Given this list of marker genes TXNDC15, RPL10, IFT122, MAPRE2, DST, SRD5A3, KCNQ1OT1, RAC1, KDM6B, TUBGCP6, SKIC3, WBP4, LRPPRC, CSGALNACT1, DOCK6, ADAR, INPP5E, ATP6V1E1, IDH1, CNTNAP1, MAFB, FOXI3, FAT4, TAF1, PGAP2, RREB1, POGZ (NCBI Gene Id 23126), PAX7, SMG9, TAF6, CCDC47, GTF2E2, SIN3A, WLS, NOTCH2, GTF2IRD2, INTU, ZNF711, SLC39A7, NDUFB11, SLC25A1, RALA, TRAIP, PGM2L1, COLEC10, HSPA9, DBR1 (NCBI Gene Id 51163), COG1, EZH2, NECTIN1 (nectin cell adhesion molecule 1), CHN1, IGLL1, PEX11B (peroxisomal biogenesis factor 11 beta), HNRNPK, THUMPD1, POC1A, POLR1A (RNA polymerase I subunit A), CCNK, AFF4, TTC8, LMNA, TCTN3, WFS1, RELN, SLC16A2, HOXA2 (NCBI Gene Id 3199), SNAP29, NEU1, PACS1, DDB1, BRCC3, RNASEH2A, DOCK7, ZEB2 (NCBI Gene Id 9839), CHRND (NCBI Gene Id 1144), PPP2R3C, CRLF1, CENPE, RFX7, DLL3, NRCAM, POU4F1, MPLKIP, BRWD3, LMNB1, TMEM138, LONP1, ARL13B, SLC25A12, CEP104, WAC, EFEMP2, RNU4-2, UFD1, MINPP1, WWOX, ALG6, GREB1L, POU3F3, INTS1, FN1, ASXL2 (NCBI Gene Id 55252), SMC1A, CTH, RFWD3, STEEP1, H19, FGD1, CEP41, CILK1, YRDC (NCBI Gene Id 79693), RRAGC, BBS12, ARID2, DHPS (deoxyhypusine synthase), COL7A1, SLC39A8, LETM1, USP7, RAB3GAP2, ASXL3, LMBRD1, RAB34, GLI3, LZTR1, FRA10AC1, FREM2, HES7, MAPK1, ADA2, AIP, RPS17, SLC12A2, RPGRIP1L, THOC2, MYO18B, UBA2, COX7B, SATB2, ERI1, CLTC, SLC37A4, MAP2K1, SKI, TTI2, CRELD1, NR2F1, DPYD, CACNA2D1, CTU2, CCDC8, MEGF8, LUZP1, KDM5B, BCL11A, ECE1, WNT9B, TCF4, PPP1CB, PUF60, CBY1, CLIP2, GLI2, LRRC8A, RASA2, RFC2, PI4K2A, ALX3, ASPRV1, HGD, PALB2, CPE, SULT2B1, VAC14, NEK1, UBAP2L, MADD, PIGN, PGAP1, AP1G1, BMP1, GFRA1, PUS7, CUL7, BLTP1, PORCN, SAMHD1, AASS, ALX1, KAT6B, SIX2, CLCNKA, TBX22, FIBP, DDX6, POMK, ANKRD11, ACTA1, EVC2, PRDM16 (PR/SET domain 16), PREPL, PSMB8, CEP290, MYMX, RPL31, COMT, KMT2A, TRIM32, ZNF668, VPS13B, BBS9, TNNT3, RNF2, PAH, PIGA, BRAF, CBL, WDR73, NDST1, CASK, NFIA, FBXL4, NSD1, DHX30, OGT, TBX1, TCF20, RBBP8, RPL8, CYP4F22, HOXB1, NDE1, NFIX, HYMAI, CARS1, ERF, ALOX12B, DRG1, GJA8 (NCBI Gene Id 2703), B3GAT3, TMEM147, B9D1, RALGAPA1, DNM1, ADAT3, ODC1, AFF2, LSS, TSHZ1, RPS15A, INPPL1, MSL3, HS6ST2, NSUN6, SPTBN1, MEIS2, HBA1, FKRP, HNRNPH1, SPECC1L, NAA20, GATA1, RNASEH2C, TRIP13, PMM2, MN1, TBX15, TGDS, KMT2C, TAF4, IFIH1, GNPTAB, FANCM (NCBI Gene Id 57697), RAB23, FANCC, NKAP, SRRM2, ADAMTSL1, ADAMTS2, TARS1, RPS10, SHANK3, CHST14, BRIP1, GLE1, FRMD4A, BAP1 (NCBI Gene Id 8314), ADSL, DLX4 (NCBI Gene Id 1751), SCNM1, SIM1, PKHD1, CWC27, EIF5A, RPL18, MBTPS1, BMP2, PDE6D, YWHAE, ALKBH8, SMCHD1, CHMP1A, RHOBTB2, ZNF148, TMEM216 (transmembrane protein 216), HYLS1, SET, PRR12, VPS35L, ARL6, TEFM, NUP107, TMCO1, COL2A1, XYLT2, PHACTR1, RAD21, PTCH1, GJA5, RAD51, GPX4, POLR3A, CIT, U2AF2, KLF13, H4C9, BLNK, RECQL4, KCTD1, DNMT3B, CAMKMT, TAOK1 (TAO kinase 1), GRB10, SLC26A2, ATR, KIF7, TUBB3, RET, MECP2, EDN1, SLC25A24, NXN, RPS27, GTF2I, TMEM237, SUFU, LMX1B, FMR1, TRMT1, SLC6A9, UBE3B, ABHD5, AMER1, MRPS2, CANT1, ZFX, ETFDH, IPO8, RBM8A, SPINT2, KLHL41, NUP88, DENND5A, PAK1, MARS2, TBC1D20, SETD1A, NR4A2, ADNP, MAD1L1, FGF3, SLC6A8, PPM1B, UBA1, AHSG, IGBP1, DVL1, ORC4, YY1, TBR1, SOX5, ACP5, UPF3B, SOST, FRMPD4, SUZ12, RXYLT1, MMP23B, XYLT1, ALG2 (ALG2 alpha-1,3/1,6-mannosyltransferase), FLNA, RNF113A, GPRASP2, FTSJ1, HDAC9, PHIP, UHRF1, ATP6AP2, SLX4, KMT2D, POLR1C, LFNG, SOS2, FGFR2, CHRNA1, SIX5, GNB1, ETFB, SMS, WDR19, AMMECR1, EEF1A2, RPS7, KYNU, FANCA, HHAT, FOXP2, SMARCD2, RPL9, NELFA, FANCI, COG5, RAB5IF, ROR2, EVC, MID2, SBDS, DZIP1L, RPL35, KIF21A, AP4E1, MRPL12, PIGV, NSRP1, C12orf57, RPL35A, SEPTIN9, COL5A1, AHDC1, SLF2, FRAS1 (NCBI Gene Id 84949), ZMPSTE24, KDM5C, CLCNKB, DVL3, RIPPLY2, PIGO (phosphatidylinositol glycan anchor biosynthesis class O), CPLX1, PHGDH (NCBI Gene Id 94672), ZNF292, TBX2, C2CD3, PEX26, NAA80, AGO2, CCDC32, GK (NCBI Gene Id 2710), TASP1, UGDH, GDF11, RPS20, PLK4, KCNK4, CCDC22, FGFR3, FGFRL1, RPL11, TBL2, FANCL, TMEM231, TMEM94, GNS, INTS11, PIGL, AP3B1, VANGL2 (NCBI Gene Id 57216), ABCC8, ADAMTS15, NOTCH3, NDP, CFAP418, RAPSN, NTNG2, PNPLA6, RPS19, HSPG2, PRPS1, RNU4ATAC, CTBP1, EPG5, CUX1, EXOC2, TALDO1 (NCBI Gene Id 6888), BBS4, CASZ1, ATP6V0A2, ITGB6, SON, CSPP1, TP63, INSR, ARID1A, LAS1L, NALCN, HECW2, BRD4, MRTFA, HS2ST1, PDZD8, RSPRY1, ERLIN2, RPS28, STAG1, IFT27, DPP6, RRAS2, MGP, SHOC2, NAA10, HBA2, GON7, TOGARAM1, SALL1, BCL11B, ZNF407, ERCC4, TSR2, PEX12, EXOSC9, TRIP11, BMP4, PAX3, UMPS, RTTN, POLR1D, STAC3, NIPBL, LRP2, ORC1, BICRA, PIGT, AGRN, ITCH, DPH1, ZNF526, TWIST2 (NCBI Gene Id 117581), SNRPB, CD96, SMG8, MESD (NCBI Gene Id 23184), TRPS1, RPS6KA3, CHRNG, SLC9A6, KCNQ1, CHAT, EIF3F, DCHS1, DYRK1A (NCBI Gene Id 1859), PIGQ, PIGK, TCOF1, AIFM1, DHCR24, RUSC2, NRAS, TBX4, WARS2, RPS29, PRKG2, IGHM, JUP, DEPDC5, KIAA0586, KCNN3, CAPN15, EMC1, IFT56, KATNIP, OCRL, SLC2A10, GSC, NBN, BAZ1B, CAMK2G, SMOC1, TREX1, UBR7, ZBTB20, VPS51, ALMS1, PEX2, ALG3, MRPS14, ATP6V1B2, GPC3, SCAPER, NHS, FBXW11, ALDH18A1, PITX1, KCNH1, RB1, SP7, POLR1B, TMEM260, SMC3, MCTP2, PEX3, FUCA1, GAD1, RNASEH2B, CHD7, ZMYM2, CLIC2, H4C5 (H4 clustered histone 5), VPS53, CD79A, PIK3CA, TP53RK, EXT1, GMNN, KAT6A, RAI1, SH3PXD2B, ACAN, CHST3, ZDHHC9, RAF1, ANTXR1, DLK1, PIGW, LIPN, GRIA4, CAV1, SF3B2, TBC1D23, CASP2, EBP, ATN1, SLC12A6, LSM11, FOXG1, CENPF, ZMYND11, TRMT10A, PIEZO2, CACNA1G, GPC4, HOXA13, HOXD13, MESP2, UBE2T, FOXF1, EIF4A2, SOX6, EXOC7, DSE, MYSM1, EFTUD2, DCPS, HMX1 (NCBI Gene Id 3166), PURA, VPS37A, RPL15, SLC1A4, CEP295, COL11A1, BSND, KDM5A, LGI4, DSP, STRA6, ALG8, ERBB3, CSNK2A1, HEATR3, MKKS, ACBD5, BCOR, MVK, SOX9, HMGA2, CA2, GRIA3, BMPR1A, GPR101, ANAPC7, COL4A1, SPEG, DPF2, TPM2, AKT1, KIFBP, TOR1A, ASH1L, CDC42, FANCF, PUM1, WNT7B, CHD5, MAN2B1, HMGB3, MUSK, OTUD5, SOS1, EDNRA, CTNND2, CAPRIN1, TTC5, SSR4, COG3, SCLT1, ARL3, MED12, SPRED2 (NCBI Gene Id 200734), ZIC3, NIN, PAICS, EGFR, IFT172, MED25, WDR35, UFC1, MKS1, TRPV4, PLOD3, PLCB4, RIPK4, PIGB, TNPO2, ALX4, SLC6A17, WASHC4, KDSR, CDC6, VAMP1, HSD17B4 (hydroxysteroid 17-beta dehydrogenase 4), TCTN2, IFT81, ADAM17, PIEZO1, CDT1, NUP188, EFL1, ERCC8 (NCBI Gene Id 2075), RIC1, TAFAZZIN, RSPO2, AARS1, SMAD4, MEF2C, ERMARD, PYCR1, BBS5, FOXP1, RPL27 (ribosomal protein L27), SOX11, TCF3, PLCH1, PCGF2, KLHL40, GABRD, WNT3 (Wnt family member 3), MLXIPL, ZNF423, GJB3 (NCBI Gene Id 91028), ITGA8, CDH2, ZSWIM6, PCLO, HIVEP2, PSAT1, TRAPPC9, GLIS3, ANTXR2, SDR9C7, NUP85, NCF1, MBTPS2, AHI1, FAM20C, MYO9A, DDX3X, COG7, BCR, ORC6, WNT5A, COL13A1, TRIP12, TMEM218, GLUL, CDCA7, TFAP2B, PRKCZ, B3GALT6, PRDX1, HELLS, FGFR1, VIPAS39, STAG2, BRF1, TMEM270, H3-3A, JAG1, STT3A, IFT140, PHOX2B, CHUK (component of inhibitor of nuclear factor kappa B kinase complex), MED27, DHX37, RAD51C, ACTG1, YME1L1 (YME1 like 1 ATPase), TXNL4A, AP1S2, SLC35C1, SPI1, MED13L, MSX2, KDM4B, CHD8, POLE, RPL26, CDKN1C, MAN1B1, UGP2, RAB3GAP1, VPS33B, ADAMTSL2, MAP2K2, H4C3, KIF15, FANCE, MPDZ, ARVCF, TOPORS, TSPEAR, MAP3K7, BUB3 (BUB3 mitotic checkpoint protein), TNNI2 (troponin I2, fast skeletal type), OBSL1, EXTL3, DCAF17, CCN2, PTPRF, TENM3, ALG13, CDH11, NANS, GPT2, FANCG (FA complementation group G), ADGRG6, ABCC6, IGF2, ADAMTS18, LAGE3, HECTD4, PTEN, RAB18, TTN, OPHN1, SEMA5A, MARS1, FGF20, TMEM70, GTF2H5, KRAS, LIG4, HDAC6, TBCD, RPL5, UNC80, KIF26A, ZC4H2, MACF1, XRCC2, KANSL1, SPIN4, MITF, GP1BB, MRAS, CHD3, TTI1, PSMD12, RAP1B, SCYL2, GTF2IRD1, HDAC4, IL6ST, BICD2, GPC6, UBE2A, HRAS, STX1A, MYCN, RBMX, ARMC9, ZNHIT3, PIGS, FBN2, HUWE1, ZNF462, ACOX1, BHLHA9, OTUD6B, FOXE1, ACTB, MAPK8IP3, PDE4D, TBCE, SLC3A1, EFEMP1, PSMB10, PYCR2 (NCBI Gene Id 29920), TRRAP, SLC5A7, AGO1, SPEN, PEX14, AFF3, PBX1, PGAP3, WNT4, SNAP25, EIF4H, KCNJ11, RARB, RPGRIP1 (RPGR interacting protein 1), KCNJ5, TMEM107, PEX10, TUBGCP4, MAF, CNOT3, ENPP1, PDPN, CHSY1, BPTF, HDAC8, ANK1, POMT2, PEX16, PIK3CD, RBM10, SCO2, QARS1, ASXL1 (ASXL transcriptional regulator 1), EIF4A3, B4GAT1, RPS26, EED, ATRIP, DIS3L2, IFT52, ABCA12, PSMC3, SPRED1, PLXNA1, OCLN, FGF10, ARX, SUOX, ITGA3, TBC1D24, BBIP1, CNOT1, NIPA1, POMT1, POMGNT2, VSX1, BRCA1, DDX59, MAP1B, CLCF1, KCNK9, STXBP1, GNE, ALG12, OTUD7A, METTL5, SMPD4, TOE1, NIPA2, PRUNE1, POR, RDH11, JARID2, SOD1, TPRKB, FLI1, ETFA, CTSD, PTH1R, TWIST1, ZBTB18 (zinc finger and BTB domain containing 18), C1GALT1C1, MRPS16, CHRNA7, HCCS, BBS10, PEX6, UQCRH, PLOD1, SPART, GLB1, NF1, GATA4, PRIM1, SMC5, IGF1R, NSUN2, DHX16, EIF2S3 (NCBI Gene Id 8422), KDM3B, KDM6A, MRPS28, GJB4, KAT5, TRIO, COL6A1, SALL4 (spalt like transcription factor 4), ITGA6, WARS1, DNAJC30, ACTG2, PIGY, USP9X, PLEC, DPYSL5, PTPN11, CAMTA1, SPOP, EYA1, NARS1, ATIC, B3GALNT2, SDCCAG8, NSDHL, TCTN1, HIRA, COL11A2, ZMIZ1, GTPBP2, OTX2, SYNGAP1, PPP1R21, GNAI3, WDR4 (NCBI Gene Id 55896), ZNF699, MGAT2, FDFT1, TMEM67, LMBRD2, ALOXE3, BBS7, LARP7, ESCO2, PLXND1, TGFB3, LMOD3, CDK13, PPP1R12A, ZMYM3, PRKDC, COL3A1, CEP19, PEX5, EXT2, BMPER, MRPS22, RAP1GDS1, TUBG1, MMACHC, STAMBP, EHMT1, SUPT16H, ARID1B, EDEM3, RPS23, FBN1, COLEC11, METTL27, GRIP1, FLNB, PHF6, NAA60, BUB1, ASNS, SCARF2, SLC32A1, RYR1, TPM3 (NCBI Gene Id 91191), WNK3, BIN1, NIPAL4, ALG9, CHD4, CRPPA, ZBTB24, TMEM165, ANKH, KATNB1, KCNJ2, CAMK2A, TFE3, WDPCP, GNB2, TET3, ASCC3, FIG4, PEX19, WASHC5, DYNC2LI1, QRICH1, PIGU, VPS37D, IRX5, DAG1, CDC45, FAR1, DHCR7, PAK3, CRKL, FHL1, TBL1XR1, SYT2, ANO1, CEP57, MASP1, DOK7, SYNE1, CACNA1C, SRCAP, DHX9, ERCC6, CLCN3, DNAJC21, CHAMP1, SIAH1, PLAAT3, B9D2, FZD2, PLAA, MEG3, PLVAP, PRRX1, RECQL, PPP1R15B, LIFR, IQSEC2, WNT7A, MID1, UBE4B, BBS2, DLX5, KIF14, ERCC3, BSCL2, OFD1, BRCA2 (BRCA2 DNA repair associated), MEOX1, EXOSC2, ERCC1, FREM1 (FRAS1 related extracellular matrix 1), KMT2B, TRAF7, CPT2, TLK2, CPOX, RAB11B, CDC42BPB (CDC42 binding protein kinase beta), GALNT2, DHODH, CPLANE1, PTDSS1, FANCD2, ELN, BRPF1, ERCC2, FAM149B1, AGPAT2, EBF3, CTCF, FANCB, SCN4A, WDR37, IREB2, SMARCD1, CDK10, DACT1, LBR, HERC1, RRAS, PIGG, MCM5, PQBP1, SRY, FKTN, AEBP1, FKBP6, BLM, MTHFR, APC, NSD2, KIF11, POLA1, TGM1, PIK3R1, DDX11, RTL1, KAT8, SF3B4, CCBE1, DONSON, EP300, BUD23, TGFBR1, COG8, FBXO11, LARGE1, ATRX, BUB1B, SLC2A1, RMRP, GPKOW, CEP120, DNA2, MAD2L2, SMAD2, TUBA1A, ADAMTS3, CNTNAP2 (contactin associated protein 2), SIX1, NUP133, SMARCA2, CUL4B, B4GALT1, IL1RAPL1, KNSTRN, ESAM, MAGEL2, RERE, NEK9, PEX1, ATP2B1, BBS1, MAN2C1, PRKAR1B, SATB1, MBD5, ALDH1A2, POMGNT1, VARS1, RPS24, ACER3, RIT1, CEP152, TUBB, KCNJ1, MAB21L1, TAPT1, WBP11 (WW domain binding protein 11), CREBBP, IFT74, ITGB4, CD79B, PPP2R5D, FBLN5, PPM1D, PAX1, SETBP1, SEMA3E, CCNQ, PCDHGC4, AMPD2, TFAP2A, SEC24C, GBA1, NEXMIF, SLC18A3, PIBF1, GJA1, PLAGL1, NGLY1, RNU7-1, AGA, CNOT2, CEP55, PAM16, LZTFL1, ATP6V1A, KIAA0753, OSGEP, CENPJ, DPH2, KCNAB2, AUTS2, PAFAH1B1, PLAG1, B3GLCT, PTF1A, MYH3, MYOD1, DDR2, NEB, PEX13, ERCC5, CC2D2A, JMJD1C, TRPV6, B4GALT7, PCNT, LRP4, NARS2, SETD5, LIMK1, FOXL2, ZIC2, SOX4, SLC4A10, AP3D1, TUBGCP2, GABRA3, NPHP1, TBCK, here is a description of the gene set: An abnormality of the external ear. species: Homo sapiens Human Gene Set: HP_ABNORMALITY_OF_THE_OUTER_EAR Abnormality of the outer ear